The following is a description of a gene set: Somatic cells can be reprogrammed to a pluripotent state through the ectopic expression of defined transcription factors. Understanding the mechanism and kinetics of this transformation may shed light on the nature of developmental potency and suggest strategies with improved efficiency or safety. Here we report an integrative genomic analysis of reprogramming of mouse fibroblasts and B lymphocytes. Lineage-committed cells show a complex response to the ectopic expression involving induction of genes downstream of individual reprogramming factors. Fully reprogrammed cells show gene expression and epigenetic states that are highly similar to embryonic stem cells. In contrast, stable partially reprogrammed cell lines show reactivation of a distinctive subset of stem-cell-related genes, incomplete repression of lineage-specifying transcription factors, and DNA hypermethylation at pluripotency-related loci. These observations suggest that some cells may become trapped in partially reprogrammed states owing to incomplete repression of transcription factors, and that DNA de-methylation is an inefficient step in the transition to pluripotency. We demonstrate that RNA inhibition of transcription factors can facilitate reprogramming, and that treatment with DNA methyltransferase inhibitors can improve the overall efficiency of the reprogramming process. species: Mus musculus Human Gene Set: MIKKELSEN_DEDIFFERENTIATED_STATE_DN from publication Mikkelsen TS, Hanna J, Zhang X, Ku M, Wernig M, Schorderet P, Bernstein BE, Jaenisch R, Lander ES, Meissner A (PMID 18509334) Genes down-regulated in partially reprogrammed and pluripotent cell populations (induced, iPS; and embryonic stem cells, ES) compared to parental lineage-commited cell lines., and this is the list of marker genes: EGR2, ZEB2, TGFB1, COL6A2, GAS1, FOXP1, FGF7